Given this list of marker genes MBTPS2, ABCD2, KAT2B, CGA, LPGAT1, CHP1, CTDNEP1, IL1B, FABP3, SIRT3, DAB2, RPTOR, NR1D1, PLA2G6, NR1H3, GNAI1, MLXIPL, SCARB1 (NCBI Gene Id 949), SREBF1, CYP7A1, PAQR3, CREBL2, PRKAA1, MIR96, FSHB, NR1H4, PLIN5, MLST8, SLC45A3, PCK1, CCDC3, HTR2A, NR1H2, LDLR, MAPK1, SORBS1, WNT4, MTOR, GPLD1, PLA2G3, STARD4, RAB38, HTR2C, FGF1, QKI, MIR29B1, GPIHBP1, PPARA, SCAP, XBP1, KAT5, ABCD1 (ATP binding cassette subfamily D member 1), RDH10, BMP6, CAPN2, MID1IP1, CREB1, SIRT2, ELOVL5, INS, CD74, ABCG1, AKT1, IFNG, AVPR1A, STAR, SPHK2, ACSL3, PTGS2 (prostaglandin-endoperoxide synthase 2), PRKACA, ABCG4, APOA4, NR5A2, ZBTB20, TNF (NCBI Gene Id 7124), KPNB1, MFSD2A, ZNF750, SLC27A1, MIR182, SIRT4, AVP, APOC2, ADM, CCN1, POR, ADGRF5, APOE, PRKCD, ENPP7, SREBF2, ABHD6, HTR2B, OGT, DGAT2, PLAA, HSD17B13, CNEP1R1, APOA5, here is a description of the gene set: Any process that activates or increases the frequency, rate or extent of the chemical reactions and pathways resulting in the formation of lipids. studied in species Homo sapiens Human Gene Set: GOBP_POSITIVE_REGULATION_OF_LIPID_BIOSYNTHETIC_PROCESS